The following is a description of a gene set: species: Mus musculus from publication Chen Y, Wang X (PMID 31504780) Genes predicted to be targets of miRBase v22 microRNA mmu_miR_465b_5p in miRDB v6.0 with MirTarget v4 prediction scores > 80 (high confidence targets). Mouse Gene Set: MIR_465B_5P, and this is the list of marker genes: Gucy1a1, Gm16445, Slco2b1, Wdfy3, Mdh1, Nup62, Thoc2, Mmp24, Cpne8, Ube2s, Septin10, Gpr21, Hopx (HOP homeobox), Pigp, Entr1, Pof1b, Rev3l, Casp8, Tacc2, Fnip1, Snrpg, Irf2 (interferon regulatory factor 2), Kitl, Samt1, Tspan14, Secisbp2l, Tle4, Pla2g3, Celf3, Treml1, Avl9, Sim1, Tjp1, Adam28, Rbfox1, Phf3, Fgd4, Foxb1, Gabrg1, Cyp20a1, Samt1b, Kcnj2, Itgb3bp, Exph5, Nup205, Lin28b, Esp31, Gosr1, Acbd5, Trub1, Naa30, Ythdc2, Arrdc3, Mcm8 (minichromosome maintenance 8 homologous recombination repair factor), Ube2w, Klhl12, Osbpl1a, Gins3, Efcab14, Epm2aip1, Tcf12, Eny2, Rnls, Eif4e, L2hgdh, Tra2b, Msl3, Hnrnpr, Mpp7, Adhfe1, Rnf113a2, Boc, Kndc1, Ehmt1, Alg14, Sypl1, Syde2, Snx13, Tti2, Nudt4, Zfp809, Cpeb2, Naaladl2, Tex12, Nhs (NHS actin remodeling regulator), Zdbf2, Zfp738, Tiprl, Trappc6b, Ptprk, Zmiz1, Rsf1, Osbpl8, Esp18, Crebrf, Nhlh2, Depdc7, Morn1, Lca5, Baz2a, 1110004F10Rik, Zfp148, D17H6S53E, Card19, Foxa2, Unc93a (unc-93 homolog A), Oat, Ap3s1, Wnt5b (wingless-type MMTV integration site family, member 5B), Cdkl4, Kpna3, Alg6, Irf6, Samt1d, Sox6, Scn1a, Pla2g5, Strap, Txndc5, Pank3, Efhc1, Vta1, Rab14, Mark3, Sbno1, Sgpp1, Smc3, Kcnab1, Yipf3, B020004C17Rik, Noxo1, Psmd11, Vwc2, Zfp248, Dgkb, Ptk2, Il1rap (NCBI Gene Id 319228), Hspa4, Gm10778, Ms4a2, Slc25a22, Btbd1, Trib2, Serpinb11, Cyp4a31, Ehd4, Cngb1, Ccdc88a, Tspan13, Nt5e, Cd9, Zfp60, Srrm1, Prkcd, Ppfibp1, Batf, Trim30b, Myo19, Gabra4, Cyp2j6, Lrrc57, Samd8, Fbxl17, Krt6a, Samt1c, Ubl3, Oaz1, Ccdc87, Smarca1, Esp34 (NCBI Gene Id 100126773), Pex13, Stag2, Pramel12, Gucy1a2, Corin, Socs6, Dmrta1 (NCBI Gene Id 242523), Ccdc85a, Mlx, Jam3, S2bpcox16, Ranbp3l, Capn3, Lrrtm2, Gria4, Zfp729b, Dpyd, Fam76b, Ptbp3, Gmcl1, Stc2, Cbx8, Lin9, Ints5, Cdh5, Lrrtm4, Fam185a, Pcdh9, Gabra6, Ankra2, Tecrl, Parp8 (poly (ADP-ribose) polymerase family, member 8), Mogs, Tmtc3, Lyn, Kera, Phf8 (NCBI Gene Id 320595), Zfp747, Mpp4, Mtdh, Csn1s1, Pak1, Ltn1, Sec11c, Cntn3, Mmd, Dip2a, Aplf, Krtap15-1, Actl6a, Pfkfb2 (NCBI Gene Id 75925), Fbxo4, Hand1, Mat2b, Cfap20, Hs3st3a1, Armcx5, Gpr85, Acadsb, Slc7a11, Susd6, Pwwp3b, Zfpm2, Ugt2a3, Glcci1, Cox16, Lhcgr, Actr2, Chic1, Cxadr, Rfx3, Sqor, Napepld, N4bp1